The following is a description of a gene set: Genes down-regulated in comparison of unstimulated CD8 T cells at 24 h versus CD8 T cells at 24 h after stimulation with IL12. Differentiation of naive CD8 T cells into cytotoxic effector cells requires three distinct signals- antigen (signal 1), costimulation -B7-1 (signal 2) and cytokine, either interleukin-12 or interferon-a/b (signal 3). Interaction of naive CD8 T cells with antigen and B7-1 programs cell division and proliferation whereas the presence of cytokines- IL-12 or IFNa/b promote survival, differentiation and memory establishment. In the absence of signal 3, the cells interacting with antigen/B7-1 undergo tolerance induction. The objective of this study was to elucidate the mechanisms how the provision of signal 3 promotes differentiation and averts tolerance induction in CD8 T cells. Trichostatin A is a pharmacological agent that inhibits histone deacetylase activity, hence regulating chromatin structure and gene expression and differentiation in many cell types. Gene signature profiles of IL-12, IFNa/b and trichostatin A stimulated cells were compared to elucidate the molecular mechanisms of gene regulation. Oligonucleotide microarray analysis is carried out to determine the extent and molecular nature of the CD8 T cell differentiation program induced by IL-12 or IFNa/b in concert with antigen and B7-1 signal. Human Gene Set: GSE15930_STIM_VS_STIM_AND_IL12_24H_CD8_T_CELL_DN from publication Agarwal P, Raghavan A, Nandiwada SL, Curtsinger JM, Bohjanen PR, Mueller DL, Mescher MF (PMID 19592655) studied in species Homo sapiens, and this is the list of marker genes: GFM2, PMM2, RAX, RPS6KA4, SLC22A12, IDO1, GJA4 (NCBI Gene Id 2701), TENM1, IL10RA, RENBP, EPO, NKAIN1, ZNF444, SLC22A6 (NCBI Gene Id 9356), MCM5, TPBG, NDUFB10, PHKG1, HTR3A, UBE2K, MSH3, PNLIPRP1, MATN3, MARK4, IFNB1, SLC35A2, HDAC1, EPHB2, RAD52, STX2, PKNOX1, ISG15, IRAG1, DUT, PSTPIP2, OPRD1, IGFBP6, SLC23A2, FAM151A, HAX1, RGS4, MYL6B, GNA14, GATA1, MRPL38, AFG2A, CCDC6, PGAM2 (phosphoglycerate mutase 2), UBALD2, SCX, NCOA1, NR0B2, RYK, POLR3D (RNA polymerase III subunit D), GRIA3, FUT1 (NCBI Gene Id 2523), SFTPC, SDSL, PON1 (NCBI Gene Id 5444), SAA4, HLA-DOB, HCRT, TBC1D23, REG3G, POLR3A, SYT7, SEC22B, KCMF1, NACC2, GPM6B, EPHB6, PCDH7, DIAPH1, IRS2, DNAJA2, MYO10, MSI1, ZDHHC9, H3C7 (H3 clustered histone 7), IL1R1, ZNF23, FKBP5, KCNK3, SRMS, FAM110A, TRHR, SEC23A, RBFOX2, ZNF574, INPP1, UBA7, P2RX6, GAA, KRT12, DPF3, EFNA5, SYNGR2, MYT1, KLF12, KRT2, NLRX1, SLC38A4, FOSB, NRCAM, MIF4GD, LGI4, MYH14, TEX264, IBSP, P3H3, THOC7, IL1RAP (NCBI Gene Id 3556), LRBA, IL5, ITGAV, PENK, NAA11, GSC, IGFBPL1, RAD23A, PTGS1 (NCBI Gene Id 5742), NAA80, EIF2B4, EIF3B, DMRTB1, PRAF2, GNPTG, MEST, GSPT2, TMT1A, INHBC, REXO5, NUP62, GJA1, IL1A, SLC44A4, METTL18, SLC30A1, TNFRSF1A, LRP6, ROBO3, RTN1 (NCBI Gene Id 8108), EOMES, G0S2, GJC1, KLF4, FBXW2, PRPF39, NHSL2, PDGFRB, LCAT, SEMA6C, NTN1, DNAJA3, UFD1, PRR15, KAT7, DVL2, RYR3, IER3, EFNA3, LTBP3, ODF1, POP4, PRUNE1, HOXB7, RUNDC3A, NCK2, ELAVL4, MFNG, KRTDAP, THBS3, DKK3, TUSC2, RFK, SAR1A, SIRT2, OMD (osteomodulin), TFEB, PEMT, IL4, TTF1, RARS1, OR6A2, POU3F3, IFIT3, FZD9, MBL2, GOLGA4, LAMA4 (NCBI Gene Id 3910), NPPC, ZNHIT3, HPGD, MRPS18B, IL9, MYO1C, SLC25A3, NQO1, GP9